Given this list of marker genes IKBKG, CD40, MAP3K7, IKBKB, CHUK, RELA, MAPK8, ERBIN, EPHB2, here is a description of the gene set: species: Homo sapiens Human Gene Set: WP_NODLIKE_RECEPTOR_NLR_SIGNALING Nod-like receptor (NLR) signaling